Given this list of marker genes C18orf63, ZNF831, HACD4, ENOX2, ARHGAP29, KPNA3, CAMSAP1, YWHAH, KIAA0408, RPS27L, PRKDC, CAMTA1, PARP1, CDYL, GAPT, SNRPA1, QNG1, ZSWIM6, ST6GAL2, PCSK2, PAK5 (p21 (RAC1) activated kinase 5), IVNS1ABP, SRI, CGGBP1, GRK5, MLLT10 (MLLT10 histone lysine methyltransferase DOT1L cofactor), TTC39C, OSMR, PPP6C, GOLGA7, CELF2, TTC33, DSC2, RAB1A (RAB1A, member RAS oncogene family), STK38, CFLAR, TET3, ERICH1, IL6, ACKR3, BMPER, CREBRF, PLAA, CA8, TEX30, FNIP1, POMP, RNF20, SS18, PTPRQ, PGAP1, TOPBP1 (NCBI Gene Id 11073), RTBDN, TBR1, ZBTB33, MAP2K1, TPD52L3, COL25A1, ZFHX4, COPS3 (NCBI Gene Id 8533), PLD5, KRCC1 (NCBI Gene Id 51315), MBNL3, GLCCI1, WNK1, NPY1R, HMGCR, ZBTB10, TGFBR3, GNAQ, VAMP7, NEXMIF, SLC25A53, SRSF3, KMT2C, PIERCE2, GVQW3, FBXO28, TLCD5, SERTAD4, LRRC8B, SCAF11, SFRP2, CBLN1, PLEKHB2, B4GALT6, ADCYAP1, CDH6, ABCA8, SPO11, FAM151B, FAM168A, KLHL7, CPD, TMC7, PATJ, TNFRSF19, ARHGEF7, ATXN3, SLAIN2, PPAT, ASIC2, ADCY2, G3BP2, DPP10, SETD4, SLITRK6 (SLIT and NTRK like family member 6), SSR1, BNC2, CSE1L, ITPRID2, KHDRBS1 (NCBI Gene Id 10657), DDX4, USH2A, GPM6B, CALU, ZNF286B, TRAPPC8, KDM7A, STMN2, HMX2, STK26, DNAJB2, GINS1, SPTSSA, TMPO, MYO6, NCKAP1, ATXN10, PSIP1, ZNF615, AKAP11, PABPC4L, UVRAG, MYNN, SLC25A36, EPN2, HHIP, TP53INP1, KDM4C, DDX3X, RCC1, GPM6A, HSPA4L, ZBTB20, KICS2, ARHGAP32, NAV3, BBOF1, IL1R1, AZIN1, TPRG1, HMGN2, FKBP4, QKI, AAK1, TNPO1, CNTNAP4, ATAD2B, SRGAP1, GLOD4, MIXL1, HNRNPF, PTPRG, BCLAF1, DENND4A, SCN9A, FGFR2, MIER3, SMC6, TEK, PGRMC1, COL11A1, ARL6IP1, TMEM135, RTL6, TSC22D2, PPP1R12B, CLEC7A, SPTSSB, MCM9, PTPRD, MARCHF8, TEC, U2SURP, PHIP, CRMP1, EEA1, GLI3, GPATCH2L, WDR36, PEG10, GID4, AGGF1, STRN, IGF2BP3 (NCBI Gene Id 10643), KCNAB1, PWWP2A, MAN2A1, CLOCK, PHF6, RICTOR, PRDM10, IKZF2, ASIC5 (acid sensing ion channel subunit family member 5), MANEAL, SIX4, CDK17, TTN, GRHL2, PNRC1, C8orf34, FSD1L, LY75, EFNB1, DDX3Y, SPRED1, UBE2W, IKZF5, IRS1, ODC1, ARHGAP21, PHC3 (polyhomeotic homolog 3), CXCL1, CPB2, TBCEL, TKTL2, UBA5, METAP1, ZBTB44, STRN3, RAD17, SULF1, SMARCA1, BTBD3, ANKRA2, FUT9, SOCS7, SGCD, ZNF70, PRKD1, ATP2B1, ATF7IP, PTPRO, CASP8AP2, FAM118B, KPNA4, FRS2, RYBP, SAYSD1, DNAJA2, SULF2, CMPK1, VSIG1, PPTC7, STT3A, MAT2B, MTMR6, FOXM1, VASP, LMAN2L, CNOT1, ANKRD44, CAND1, ATG14, FAM13C, PRPF40A, SREK1, ARFGAP3, ILRUN, KCTD12, PIP5K1B, DUSP7, PRMT9, ABHD17B, ETS1, PEX5, PAQR9, RFX2, KLHL15, PRKAA2, SLC2A13, TMEM170A, CHSY3, ZMAT1, SCAF4, MFF, RIDA, PLGRKT, PRRG1, ACSS3, ZNF518A, VGLL3, CDH7, USP47 (NCBI Gene Id 55031), INPP5F, LRP2BP, RBBP5, PELI1, NFXL1, LARP4B, FANCB, TOMM20, NUP58, CD200R1, JMY, CRY1, CYP3A4, ZNF286A, NR2F2, NTAQ1, ARPP19, DENND1A, GATM, C2orf49, EEPD1, XPO4, DCC, LPP, KCTD10, TARDBP, here is a description of the gene set: Human Gene Set: MIR1323 from publication Chen Y, Wang X (PMID 31504780) Genes predicted to be targets of miRBase v22 microRNA hsa-miR-1323 in miRDB v6.0 with MirTarget v4 prediction scores > 80 (high confidence targets). species: Homo sapiens